Given this list of marker genes GBF1, FBXO8, MAP4K4, ARFGEF2, PSD, CYTH1, ARFGEF1, MAPRE2, GIT1, GIT2, MYO9B, ARFGAP1, ARFGEF3, PSD4, IQSEC1, IQSEC3, PSD3, PSD2, CYTH4, CYTH2, CYTH3, IQSEC2, here is a description of the gene set: Human Gene Set: GOBP_ARF_PROTEIN_SIGNAL_TRANSDUCTION species: Homo sapiens An intracellular signaling cassette in which a small monomeric GTPase of the ARF subfamily relays a signal.